Given this list of marker genes Notch1, Gpld1, Vegfb, Sec1, Smad1, Vstm4, Tbxa2r (thromboxane A2 receptor), Tgfb1, Rtn4, Naxe, Apela, Ghrl, Hdac5, Cdh5, Aplnr, Fgfbp1, Mmrn1, Il12a, Pdpk1, Tgm2, Cib1, Hif1a, Itgb1, Clic3, Nr2e1, Spred1, Tmem215, Vegfd, Cemip2 (NCBI Gene Id 83921), Fgf1, Vegfc, Nr4a1, Sh2b3, Ngfr, Parva, Tspan18, Adtrp, Grem1, Flt4, Glul, Egr3, Tnn, Hmox1, Akt3, Adgra2, Eng, Agtr1a, Rspo3, Hdac9, Fut1, Ghsr, E2f2, Adamts9, Pdcd10, Gata2, Map3k3, Pik3cb, Srpx2 (sushi-repeat-containing protein, X-linked 2), Slit2, Dsg2, Jmjd8, Itgb1bp1, Synj2bp, Sema3e, Cdc42, Ctnnd1, Clec14a, Tgfbr3, Sema6a, Prl2c2, Jmjd6, Akt1, Pik3c2a, S100a1, Robo1, Vegfa, Mmrn2, Bmper, Micall1, Ppp1r16b, Ehd4, Tek, Shh (sonic hedgehog), Dll4 (delta like canonical Notch ligand 4), Itga5, Alox5, Klf4, Efnb2, Epha2, Bmp4, Tjp1, Jak1, Thbs1, Epn1 (NCBI Gene Id 13854), Ceacam1 (CEA cell adhesion molecule 1), E2f7, Abl1, Rhoj, Stard13, Flvcr2, Otulin, Zfp354c, Anxa1, Ptgs2, Hdac7, Epn2, Pkm, Jcad, Cdh13, Meox2, Nrp1, Ptk2b, Angpt1, Creb3l1, S2bpcox16, Ccbe1, Dll1, Esm1, Slc39a12, Lef1, Map2k5, Flt1, Yjefn3, Reck, Agtr1b, Ephb4, Pacsin2, Klf2, Fbxw7, E2f8, Sema5a, Ramp2, Il10, Kdr, Nrarp, Pgf, Foxc2, Rnf213, Loxl2, Fgf2, Plk2, Rhoa, Mia3, Pik3r3, Card10 (NCBI Gene Id 105844), Pik3r2, Srf, Hmgb1, Il12b, here is a description of the gene set: studied in species Mus musculus Mouse Gene Set: GOBP_SPROUTING_ANGIOGENESIS The extension of new blood vessels from existing vessels into avascular tissues, this process includes the specialization of endothelial cells into leading tip and stalk cells, proliferation and migration of the endothelial cells and cell adhesion resulting in angiogenic sprout fusion or lumen formation.